Given this list of marker genes WIPF1, FGL2 (fibrinogen like 2), RPS4Y1, TGFBR3, GFRA3, LIMCH1, LINC02256, PRSS23, MIA, PLEKHA4, PTX3, GJC3, TRPM3, FSTL3 (follistatin like 3), GPNMB, GPR17, NTM, OLFML2A, COL15A1, IL11RA, SFTPC, BMF, SH3D19, COL4A1, RXRG, FRMD3, HSPG2, MARCHF3, BGN, RAB20, MAL2, RASGEF1C, DNASE2, NIBAN1, CD44, SEMA3G, ASPA, AATK, EEIG1, USP53, VAMP5, SLC16A4, SORBS1, COL16A1, PON2, EMP3, DOCK5, ITGA1, NFIX, TMEM71 (transmembrane protein 71), ST6GALNAC2, CYBRD1, S100A11, ENTPD2, AHNAK, RGS10, IFITM2, LGALS3, RNASE1, MYL9, IGFBP7, FADS3, FST, PDGFC, LAMP5, NAALADL2, SAMHD1, RBM43, TMEM176B, SHFL, IQGAP2, TPBG, AQP1, FBLN2, CDC42EP5, TMEM176A, PLSCR4, CCL2, MATN2, COL28A1, SOCS3, EGFL8, BHLHE40, TSPAN11, MAL, ART3, COL5A3 (NCBI Gene Id 50509), SMIM5, FBLN5, RNASE4, SCN7A, LAMB1, HTRA1, XKR4, FIBIN, ALDH1A1, DEPDC7, here is a description of the gene set: Late Schwann from publication He P, Lim K, Sun D, Pett JP, Jeng Q, Polanski K, Dong Z, Bolt L, Richardson L, Mamanova L, Dabrowska M, Wilbrey-Clark A, Madissoon E, Tuong ZK, Dann E, Suo C, Goh I, Yoshida M, Nikolić MZ, Janes SM, He X, Barker RA, Teichmann SA, Marioni JC, Meyer KB, Rawlins EL (PMID 36493756) Human Gene Set: HE_LIM_SUN_FETAL_LUNG_C7_LATE_SCHWANN_CELL species: Homo sapiens